Given this list of marker genes AK7, DNHD1, CFAP44, DRC1, DNAH10, USP26, SPACA1, ARMC2, CFAP58, CFAP91, CYLC1, CFAP61, TTC21A, STK33, WDR19, FSIP2 (NCBI Gene Id 401024), CATIP (NCBI Gene Id 375307), QRICH2, SSX1, DNAH17, CFAP65, LRRC23, KCNU1, SPEF2, DNAH7, TTC29, DNAH1, DNAH8, CFAP251, CFAP43, DNAH2, AKAP3, CFAP69, CFAP74, CFAP47, CCDC146, here is a description of the gene set: Sperm cells whose flagella are twisted (coiled). species: Homo sapiens Coiled sperm flagella Human Gene Set: HP_COILED_SPERM_FLAGELLA